The following is a description of a gene set: The directed movement of lipid molecules passing through the blood-brain barrier. studied in species Homo sapiens Human Gene Set: GOBP_LIPID_TRANSPORT_ACROSS_BLOOD_BRAIN_BARRIER, and this is the list of marker genes: FABP5, MFSD2A, CD36, SLC27A1, APOE, SLC27A4